Given this list of marker genes IGKC, CIITA, POLR3F, BLM, STAT1, NFKB2, REL, UNC93B1, TPP2, WAS, CD3E, MBL2, POLD1, RFXANK, ICOSLG, RFXAP, TAPBP, CD247, IGHG2, CD3D, UNC119 (unc-119 lipid binding chaperone), DPP9, RFX5, ARHGEF1, IL2RG, FCGR3A (Fc gamma receptor IIIa), CASP8, here is a description of the gene set: studied in species Homo sapiens Human Gene Set: HP_UNUSUAL_VIRAL_INFECTION Unusual viral infection